The following is a description of a gene set: Human Gene Set: KEGG_MEDICUS_PATHOGEN_HPV_E6_TO_NOTCH_SIGNALING_PATHWAY_N00382 studied in species Homo sapiens Pathway Definition from KEGG: E6 -> (NFX1+PSEN1) -> NOTCH -> (NICD+RBPJ+MAML) => (HES1,HEY1) HPV E6 to Notch signaling pathway. Pathway ID: N00382. Pathway type: Pathogen. Pathway class: nt06511 NOTCH signaling., and this is the list of marker genes: NOTCH1, HEY1, MAML1, MAML3, PSEN1, NOTCH3, NFX1, NOTCH2, HES1, NOTCH4, MAML2, RBPJL, RBPJ